The following is a description of a gene set: Any process that results in a change in state or activity of a cell (in terms of movement, secretion, enzyme production, gene expression, etc.) as a result of a vitamin D stimulus. Human Gene Set: GOBP_CELLULAR_RESPONSE_TO_VITAMIN_D studied in species Homo sapiens, and this is the list of marker genes: GDAP1, MN1, GPRIN3, MIR125B1, FGF23, SFRP1, SNAI2, TRIM24, PIM1, PHEX, BGLAP, RXRB, KANK2, TNC (tenascin C), FES, VDR, NCOA3, CYP27B1, MED1, CYP24A1, SNW1, RXRA, CASR, PENK